The following is a description of a gene set: studied in species Mus musculus Mouse Gene Set: chr9E2, and this is the list of marker genes: Gm39384, Gm27216, Gm18487, Rps27a-ps2, Gm28552, Gm38398, Gm8226, Lca5, Ttk, Irak1bp1, Elovl4, Phip, Gm2087, Sh3bgrl2, Gm46124, Gm2109, Bckdhb, Gm2065, Gm46123, Hmgn3, Gm39388, Gm26146, Gm36120, Gm36278, Gm39383